The following is a description of a gene set: Mouse Gene Set: CUI_T_CELL_CD8_IFNA1_RESPONSE_DN studied in species Mus musculus Cytokines mediate cell-cell communication in the immune system and represent important therapeutic targets. A myriad of studies have highlighted their central role in immune function, yet we lack a global view of the cellular responses of each immune cell type to each cytokine. To address this gap, the authors created the Immune Dictionary, a compendium of single-cell transcriptomic profiles of more than 17 immune cell types in response to each of 86 cytokines (>1,400 cytokine-cell type combinations) in mouse lymph nodes in vivo. A cytokine-centric view of the dictionary revealed that most cytokines induce highly cell-type-specific responses. For example, the inflammatory cytokine interleukin-1β induces distinct gene programmes in almost every cell type. A cell-type-centric view of the dictionary identified more than 66 cytokine-driven cellular polarization states across immune cell types, including previously uncharacterized states such as an interleukin-18-induced polyfunctional natural killer cell state. Genes negatively differentially expressed in cell type: CD8+ T cell upon treatment with cytokine: IFN-α1 in mouse lymph nodes in vivo. from publication Cui A, Huang T, Li S, Ma A, Pérez JL, Sander C, Keskin DB, Wu CJ, Fraenkel E, Hacohen N (PMID 38057668), and this is the list of marker genes: Cotl1, Sri (NCBI Gene Id 73025), S100a13, Selenop, Cdkn1b, Madd, Gimap3 (GTPase, IMAP family member 3), Ppp1ca, Laptm5, Otulinl, Map4k4, Ppp2r5a, Pglyrp1, Mta3, Diaph1, Ahnak, Tprg1l, Rac2, Ogt, Ypel3, Acp5, Cdk2ap2, Lamtor4, Myh9, Btg2, Grk2, Peak1, Cd3g, Add3, Srpk2, Septin9, Saraf, Cxcr4, Itgb7, Retreg1, Sh2d1a (NCBI Gene Id 279676), Cd37, Kif21b, Cited2 (NCBI Gene Id 17684), H1f2, Clta, Cd55, Anxa5, Emp3, Ube2h, Tubb5, H2az1, Actn1, Dap, Entrep3, Luc7l2, Slc12a7, Jak1, AI467606, Ifngr1, Bin1, Septin1, Grap2, Slc25a4, Cyba, Gtf2i, Bin2, Mxd4 (NCBI Gene Id 69247), Chd3, Izumo4, Map4k2, Zmiz1, Bnip3l, Eef2, Gpx4 (NCBI Gene Id 625249), Atp1b3, Stk4 (serine/threonine kinase 4), Tmem234, Higd2a, Ncor1, Arhgap9, Flna, Gnas, Crip1, Bcl9l, Glipr1, Tsc22d3, Fam78a, Grk6, Acyp1, Gnai2, Plec, Myl6, Rasgrp1, Spn, Klf2 (Kruppel-like transcription factor 2 (lung)), Fxyd5, Tuba1a, Cdc42ep3, Fyb1, Arhgdib, Atox1, Znrf2 (NCBI Gene Id 68858), Pnisr, Zyx, Tnik, Rgcc, Ets1 (NCBI Gene Id 330916), Themis, Rgs10, Gimap6, H2aj, Tle5, Slamf6, Cd28, Pou2f2, Ankrd44, Eno1, Dock10, Klf6, Git2, Dennd1c, Zfp36l2, Gramd1a, Jakmip1, B4galnt1, Zdhhc20, Rasgrp2, Tnfrsf18, Prex1, Thy1 (thymus cell antigen 1, theta), Tln1, Gm2a, Ing1 (NCBI Gene Id 69244), Hmgb1, Klhl24, Stk17b, Pik3r1, Actg1, Supt4a, Scp2, Ctla2a, Lef1, Clk1, Vim, Stk10, Stk38, Mettl26, Ankrd12 (NCBI Gene Id 224959), Tacc1, Rcsd1, Arrb2, Rflnb, Prkcb, Smc6, Il7r, Stim1, Top2b, Ccdc107, Klf13, Gimap5, Neurl3, Hsd11b1, Arid4a, Fos, Calm2, Sgk1, Hvcn1, Galnt6, Ripor2, Sh3bgrl3, Camk4, Uba52, Ccdc88c, Tbxa2r, Sh3kbp1, Rabac1, Tnfaip8, Selplg, Tagln2, S100a10 (S100 calcium binding protein A10 (calpactin)), Gmfg, Pik3ip1, Chd6, H2az2, Itpkb, Septin6, Txnip, Eva1b, Kmt2e, Dgka (NCBI Gene Id 13139), Smc4, Trbc2, Rassf2, Ostf1, Macf1, Add1, Gpsm3, Akap13, Ttc3 (NCBI Gene Id 70444), Tspan32, Ddx17, Pik3cd, Arhgap45, Stat4, Hmgb2, Kmt2c, Tcf7, Creb1, Acaa2, Sugt1, Ramp1, Chd4, Lyst, Fmnl1, Cd3e, Pnrc1, Anp32a, Arhgef18, Paip2, Pdcd4 (programmed cell death 4), Pbxip1, Cd52, Dapl1, Lbh (NCBI Gene Id 77889), Cmah, Klrd1, Frmd8, Ccr9, Tecpr1, Arl5c, Ralbp1, Smad7, Cd7, Ctsd, Ftl1, Tbc1d10c, Ssbp3, Grap, Ier2, Klf3, Ucp2, Cnn2, S100a6, Sorl1, Adgre5, Adcy7, Fth1, Itga4 (integrin alpha 4), H1f4, S1pr1, Cd3d, Tmem108, Plcxd2, Cd5, Hcst, Hdac7, Ifi27, Rp9, Lgals1